The following is a description of a gene set: Human Gene Set: MIR6841_5P species: Homo sapiens from publication Chen Y, Wang X (PMID 31504780) Genes predicted to be targets of miRBase v22 microRNA hsa-miR-6841-5p in miRDB v6.0 with MirTarget v4 prediction scores > 80 (high confidence targets)., and this is the list of marker genes: DENND2D, ZNF749, MAGEA8, FAM120AOS, ABCA1, FAM229B, RFX4, ANKRD52, PUM1, SKIL, ATRN, TBP, COPA, UGT2B15 (NCBI Gene Id 94476), TES, CDK6, M6PR, SATB1, LMBRD2, SMPDL3A, GABBR1, VTCN1, MPP4, ADAMTS6, RPL31, IGBP1, TUT4, GALP, MPZL3, SUZ12, EXOC2, QSER1, PRR32, VPS13A, GSG1, TLCD3A, TMEM47, NAMPT, YIPF6, MARVELD1